Given this list of marker genes Cdc73, Msh6, Fshr, Cop1, Mlh1, Msh2, Hmga1, Fbxo4, here is a description of the gene set: Mouse Gene Set: MP_INCREASED_UTERUS_TUMOR_INCIDENCE studied in species Mus musculus Mouse genes annotated to increased uterus tumor incidence (MP:0009222) retrieved from the Mouse Genome Informatics database via MouseMine from publication Motenko H, Neuhauser SB, O'Keefe M, Richardson JE (PMID 26092688)